Given this list of marker genes SERPINC1, CCR1, IL12A, HLA-B, IL10 (NCBI Gene Id 3586), TLR4, IL12A-AS1, ERAP1, PROS1, MEFV, C4A, KLRC4 (NCBI Gene Id 8302), UBAC2, FAS, IFNGR1, IL23R, STAT4, PROC, here is a description of the gene set: Human Gene Set: HP_SUPERFICIAL_THROMBOPHLEBITIS Superficial thrombophlebitis species: Homo sapiens Inflammation of a superficial vein associated with venous thrombosis (blood clot formation within the vein).